Given this list of marker genes Hdac9, Sec23ip, Kcne2, Zswim6, Copg1, Ccr4, Vgll3, Ctdspl, Bcl2l2, Asxl2, Slit2, Ogfrl1, Iho1, Lcorl, EU599041, Afdn, Mtcp1, Nufip2, Cpsf7, Rictor, Fam168b, Zcchc2, Znfx1, Slc28a2, Btn2a2, Rpap1, Fam168a, Samd8, Tomm7, Usp39, Tfap2a, Pramel27 (NCBI Gene Id 194225), Gfra1, Clk2, Tasor, Selenop, Wapl (NCBI Gene Id 320218), P2ry10, Emilin3, Bicral, Gvin3, Ubash3b, Psmf1 (NCBI Gene Id 99294), Slc4a4, Zfp54, Cyyr1, Nfat5, Wnt3a, Magea9, Rspo2, Hspa13, Map3k1, Acvr2b, Braf, Aktip, Zwint, Nipal3, D630045J12Rik, Pter, Trim33, Mpzl2, Cdk12, Tmem64, Gabra1, Slc28a2b, Zfp148, Carmil1, Wrn, Dcx, Lama5, Rpe, Kbtbd6, Kdm7a, Tbc1d32, Rab11fip2, Nde1, Clec7a, Fndc7, Ercc5, Oaz2, Usp54, Snai2, Pcsk5, Zfp384, Slc8a1, Pik3ca, Pex13, Nom1, Il1b, Gtsf1, Syt14, here is a description of the gene set: Genes predicted to be targets of miRBase v22 microRNA mmu_miR_26a_2_3p, mmu_miR_26b_3p in miRDB v6.0 with MirTarget v4 prediction scores > 80 (high confidence targets). Mouse Gene Set: MIR_26A_2_3P_MIR_26B_3P species: Mus musculus from publication Chen Y, Wang X (PMID 31504780)